Given this list of marker genes TRIOBP (NCBI Gene Id 23712), CDK5RAP2, SPTA1, PAK2, OAZ3, SPECC1L, GMFG, CKAP2, TOGARAM2, WAS, SPTBN1, SSH1, KANK1, RBM14, SVIL (NCBI Gene Id 6840), WASF2, SPEF1, CAPZA1, PFN1, CORO2B, CAV3, S1PR1, NUBP1, DIAPH3, PRKCD, KANK3, IQCJ-SCHIP1, MIR138-1, TMOD1, MAP1B, MID1IP1, DYRK1A, CGNL1, ARAP1, RDX, KAT2A, GAS2L1, NAV3, BBS4, FRMD7, MYADM, PHLDB2, MDM1, TBCD, TPX2, CIB1, MIR214 (NCBI Gene Id 406996), SPTAN1 (spectrin alpha, non-erythrocytic 1), CARMIL2, WDR47, ADD2, GMFB, PIK3CA, CLASP1, LIMA1, CAPZA3, SSH3, TWF1, CAMSAP2, CTNNA2, MAPRE1, PLEKHH2, GAS2L2, MIR21, CYRIB, ARHGAP28, ATXN7, WASHC2C, TMEM67, APC, SNCA, LMOD3, MAP6D1, KANK2, BRCA1, ARPIN (NCBI Gene Id 348110), SWAP70, CLASP2, CDH5 (cadherin 5), AVIL, CFL1, INPP5J, RHPN2P1 (NCBI Gene Id 646090), HDGFL3, TJP1, SHANK1, TACSTD2, EML2, SMAD4, MIR149, F11R, HIP1R, SPTBN4, SCIN, ARHGEF2, KAT2B, SPTBN5, PFN2, MYOC (myocilin), TRIM37, ASB2, CARMIL1, CCDC88C, CAPZA2, FKBP4, SSH2, LMOD2, LMOD1, GSN, FLII, ARHGEF7, PRKN, STMN2, TRIM54, TMEFF2, TAOK1, TMOD3, CCNF, TMOD2, CORO1B, VILL, PICK1, RHPN1, CORO1A (coronin 1A), ARFGEF1, CAPZB, EPS8, APC2, VIL1, MIR20A, SLIT2, FGF13, PIK3R1, MID1 (midline 1), MKKS, NPM1, CRACD, CLIP3, DMTN, SPTBN2, TWF2, MET, DNAI3, ARHGEF18, CENATAC, SPTB (NCBI Gene Id 6710), PPFIA1, KATNB1, SHANK3, STMN1, HDAC6, TMSB4X (NCBI Gene Id 7114), TUBB4A (tubulin beta 4A class IVa), BMERB1, KANK4, INPP5K, CAPG, MTPN, TTBK2, ARHGAP6, DLC1 (NCBI Gene Id 94517), TMOD4, ADD1, ADD3, RHPN2, BBOF1 (basal body orientation factor 1), MAP2, here is a description of the gene set: Any process that stops, prevents, or reduces the frequency, rate or extent of the formation, arrangement of constituent parts, or disassembly of cytoskeletal structures. species: Homo sapiens Human Gene Set: GOBP_NEGATIVE_REGULATION_OF_CYTOSKELETON_ORGANIZATION